Given this list of marker genes Hmga2, Foxp2, Srsf6, Sox9, Cdc42, Nfib, Fgfr2, Wnt2 (NCBI Gene Id 93808), Fgf7, here is a description of the gene set: Mouse Gene Set: GOBP_REGULATION_OF_EPITHELIAL_CELL_PROLIFERATION_INVOLVED_IN_LUNG_MORPHOGENESIS species: Mus musculus Any process that modulates the frequency, rate or extent of epithelial cell proliferation involved in lung morphogenesis.